The following is a description of a gene set: studied in species Mus musculus Catalysis of the reactions: ATP + protein serine = ADP + protein serine phosphate, and ATP + protein threonine = ADP + protein threonine phosphate. Mouse Gene Set: GOMF_PROTEIN_SERINE_THREONINE_KINASE_ACTIVITY, and this is the list of marker genes: Mylk2, Pnck, Slc27a1 (NCBI Gene Id 26457), Wnk2, Ccnjl, Itpka, Dazap2, Ccni, Cdk6, Prex1, Map3k8, Prkg2, Mapk7, Irak4, Strada, Tbk1, Cdkl2, Clk4, Fastk, Igf1, Ksr2, Smok3a, Lgals9, Dclk3 (NCBI Gene Id 245038), Mapk14, Map2k7, Raf1, Ccnb2, Nek5, Uhmk1, Tssk1, Mob1b, Camk1, Pak2, Mos, Map3k14, Cdk5, Pak5, Tssk4, D1Pas1, Mast4, Pdk2, Prkcz, Cdkn1a, Igf2, Map2k5, Gak, Elp3, Prkar1a, Cab39, Irak3, Stk39, Dapk3, Cks1brt, Prkx, Map2k1, Brsk2, Adck2, Prkdc, Cdk20, Irgm2, Sgk2, Pkmyt1 (protein kinase, membrane associated tyrosine/threonine 1), Plk3, Rps6ka3, Brd2, Lrrk1, Mark1 (NCBI Gene Id 98697), Nos2, Srpk2, Tnni3k, Ccnb3 (NCBI Gene Id 209091), Wnk1, Map3k6, Pim1 (proviral integration site 1), Adck1, Brd4, Stk3, Myo3a, Pkn3, Pdk1, Pik3cg, Mtor (NCBI Gene Id 80612), Camk2n2, Map4k3, Tlk2, Etaa1, Wnk3, Tcl1b2, Ripk1, Cdk17, Mapk8, Acvr2a, Camk1g, Ciita, Igtp, Parp16, Cdc7, Cdk19, Acsl1, Map2k4, Pim2, Alpk3, Cdk10, Bmp4, Sik1, Tgfbr3, Tcl1b5, Prkcq, Mlst8, Hipk1, Pgk1, Rheb, Mylk4, Cks1b (NCBI Gene Id 99474), Rps6kc1, Tnik, Map4k4, Ikbkb, Stradb, Tgfbr2, Cdk7, Gsk3b, Ltf, Cdkl5, Dclk2, Cd40lg, Eif2ak4, Hipk4, Blvra (biliverdin reductase A), 4921509C19Rik, Grk3, Acvr1c, Nrk, Rps6ka6, Stk4, Speg (NCBI Gene Id 98673), Map3k19, Ddx3x (DEAD box helicase 3, X-linked), Pdk3, Ccnb1, Plk4, Spred2, Pkn2, Chek2, Tab1, Elp4, Nek11, Cdc42bpb, Map3k13, Vrk1, Prkag1, Mtcp1 (NCBI Gene Id 547409), Dbf4, Lmtk3, Spred1, Tcl1b1, Riok1, Parp8, Atr, Nek3, Ccnb1-ps, Tgfbr1, Atad3a, Grk2, Cdkn2b, Stk26, Ulk3, Taok2, Dyrk2, Bmpr1b, Pink1, Gdf2, Cdk14, Ulk2, Stk17b, Macroh2a1, Map3k7, Dele1, Nek10, Phkg2, Stk35, Nek1, Map2k3, Csnk1g2, Rps6kl1, Mapk9, Camk2d, Nek4, Lmtk2, Cib1, Map4k5, Ccnd2, Mapk11, Tcl1, Grk5, Aurka, Gcn1, Akt3, Dab2ip, Prkch, Calm3, Prkaca, Prkab1, Lrrk2, Ccng2, Cdk15, Chek1 (NCBI Gene Id 97555), Spry2, Bmpr2, Trp53rkb, Sik3, Sgk3, Ccng1, Inka2, Atg13, Ern2, Mark4, 1810024B03Rik, Dapk1, Ccnl1, Cdk9, Clk3, Grk4 (NCBI Gene Id 80675), Pask, Braf, Rad50, Mak, Oxsr1 (oxidative-stress responsive 1), Cdkn2a (NCBI Gene Id 18560), Calm1, Ccnl2, Fermt2, Hjv, Camk1d, Ccnd1, Map3k4, Cdc42bpg, Hspa5, Mok, Cdk2, Cdkn2c, Mylk3, Camkv, Pkm, Bmp2 (bone morphogenetic protein 2), Dyrk1b, Prkg1, Camk2g, Mknk2, Cnppd1, Cilk1, Aurkc, Eif2ak2, Irak1, Mapk4, Hspb1, Trp53rka, Snrk, Stk24, Sbk2, Nuak2, Fam20c, Phkg1, Cdkl4, Dyrk4, Nek2, Pim3, Cdkn1c, Aurkb, Pkn1, Tssk2, Vrk3, Taf1, Mast2, Cdkn1b, Stk36, Map4k2, Cdk4, Mapk12, Prkar1b, Kat2b, Prkacb, Cdk8, Rock1, Bckdk, Eif2ak1, Map3k5, Cdk12, Trio, Smok2b, Cpne3, Mapkapk3, Iqgap1, Taok1, Cdkn2d, Smok3b, Tlk1, Sav1, Camkk2, Smo, Pak4, Prkab2, Ccne2, Pik3r4, Map3k3, Prkag2 (protein kinase, AMP-activated, gamma 2 non-catalytic subunit), Gm4922, Grk1, Dclk1, Camk2b, Nrbp1, Deptor, Pak3, Prkaa1, Pdk4, Sbk3, Stk31, Riok2, Bcr, Rps6kb2, Syk, Dcaf1, Cdk13, Stk10, Csnk2a1, Top1, Rictor (NCBI Gene Id 78757), Ripk3, Rps6ka4, Prex2, Ttbk2, Atm, Sgk1, Sostdc1, Ccnh, Riok3, Ccnj, Cdk11b, Als2, Stk25, Pbk, Nek6, Ccna1, Ppef2, Ccne1, Dstyk, Map2k2, Mylk, Ptk2b, Adck5, Tssk5, Htatip2, Map3k2, Ulk4, Ern1, Tssk3, Nuak1, Map3k10, Ttbk1, Prkaa2, Lats1, Nme2, Mast3, Mnat1, Prkd3, Akt2, Prkci, Stk33, Csnk2b, Mast1, Rps6ka2, Csnk2a2, Nrbp2, Gm7358, Acvr1, Eef2k (eukaryotic elongation factor-2 kinase), Map3k1, Cab39l, Ulk1 (NCBI Gene Id 22241), Grk6, Stk32b, Adipoq, Gsk3a, Cdk5r2, Lats2, Ccna2, Pskh1, Bmp2k, Cks2, Nek9 (NCBI Gene Id 353030), Prkar2a, Camk4, Cit (NCBI Gene Id 320895), Rps6kb1, Sik2, Cdk18, Nek8, Map3k20, Tex24, Brsk1, Prkd1, Ankk1, Tgfb1, Gm14151 (predicted gene 14151), Rps6ka5, Trpm7 (NCBI Gene Id 80648), Slk, Srpk1, Prkag3, Camkk1, Tgfbr3l, Ikbke, Stk38, Prpf4b, Mapk1, Cdk16, Bmpr1a, Prkcg, Hexim1, Prkca, Mapk3, Ripk2, Tssk6, Hipk2, P2rx7, Eif2ak3, Map3k12, Mob1a (NCBI Gene Id 338504), Tnk2, Mstn, Rock2, Nbn, Pak1, Myo3b, Inca1, Chuk, Csnk1d, Inka1 (inka box actin regulator 1), Smg1, Acvrl1, Topbp1, Ccny, Ccnf, Pik3ca, Acvr2b, Map4k1, Mark3, Stk19, Cdk3, Akt1, Ccdc88a, Parp6, Stk38l, Smok3c, Limk1, Prkcb, Map3k15, Mastl, Nlk, Pkig, Clk1, Plk2, Haspin, Camk2n1, Srpk3, Bub1, Stk16, Nim1k, Pikfyve, Aatk, Prkd2, Ly6g6e, Ccnt1, Pak6, Akt1s1, Amhr2, Irgm1, Tesk1, Prkar2b, Cdk1, Obscn, Mapk13, Cdk5r1, Mink1, Limk2, Sbk1, Ripk4, Cdkl1, Pdpk1, Bmp7, Mknk1, Mapkapk2, Hmgb1, Trpm6, Pmp22, Rptor, Pdik1l, Aak1, Cdkl3, Nek7, Csnk1g1, Map3k11, Stk-ps2, Dapk2, Stk40, Calm2, Acvr1b, Csnk1e, Melk, Stk32a, Mapk10, Cdc42bpa (CDC42 binding protein kinase alpha), Alpk1, Tesk2, Wnk4, Gm7168, Pkib, Bub1b, Smok2a, Tcl1b3, Prkce, Mapk15, Ccnc, Ankrd42, Vrk2, Stk11, Stk32c, Prkcd, Araf, Csnk1a1, Htra2, Ksr1, Camk2a (NCBI Gene Id 98128), Samd15, Csnk1g3, Ccnk, Kalrn, Mark2, Alpk2, Ilk, Rps6ka1, Plk1, Ccnd3, Mlkl, Taok3, Ccnt2, Ttn, Map3k21, Stkld1, Gm7356 (predicted gene 7356), Pkia, Fam20a, Rskr, Ccno, Ttk, Clk2, Cask, Map3k9, Ccnq, Dyrk1a, Dyrk3, Tcl1b4, Hipk3, Mapk6, Casp3, Hunk, Hexim2, Map2k6, Dmpk, Mapkapk5